Given this list of marker genes Majin, Terb2, Spo11, Rad21l, Sun1, Nup98, Ube2b, Cep63, Spdya, Mlh1, Atm, Terb1, Terf1, Mei1, Kash5, here is a description of the gene set: species: Mus musculus Mouse Gene Set: GOBP_TELOMERE_LOCALIZATION Any process in which a telomere is transported to, and/or maintained in, a specific location.